Given this list of marker genes CELF2, IGSF3, RASSF4, HEY1 (NCBI Gene Id 23462), CHRND, RAPSN, POU4F1, SCN3B, JAG2, PCDH17, TNNT3, SLC24A3, MYCL, FGFR4, SEMA6A, VWF, CACNA2D2, ATP2A1, IGF2, NES, ATP2A3, CLCN5, PLXNC1, NDRG2, MYCN, NCOA1 (NCBI Gene Id 8648), FGF9, PTBP2, SYNPO2L, NCAM1, PPP1R16B, NCALD, MAB21L1, SYNE2, PCMTD2, CDH15, KCNN3, DES (NCBI Gene Id 497658), TMOD1, TFAP2B, RYR1, RRAGD, ALPK3, DCX (doublecortin), MEOX1, ZBTB18, TNNI1, AGPAT5, SIRT2, GNAS, SOX11, CHD7, POGZ, PKIA, NHLH1, EYA2, CASQ2, ITM2A, MYOG, DIO2, CHRNB1, TSPAN12, RBM38, SIK1, NRCAM, CEBPA, SGCA, PKP4, SIX1, MYL11, RPL31, ZNF536, EYA1, POPDC3, TNNI2, RTN2, TPPP3, SRSF7, ZNF106, SPINT2, ASXL2, MYOD1 (myogenic differentiation 1), BIN1 (NCBI Gene Id 274), PIPOX, TGIF2, DMPK, TUBB2B, CNR1, TNNT2, RNGTT, COBL, PDE2A, TNNC1, CDKN1C, ARPP21, ERBB3, FOXN3, CYFIP2, ENO3, here is a description of the gene set: from publication Ren YX, Finckenstein FG, Abdueva DA, Shahbazian V, Chung B, Weinberg KI, Triche TJ, Shimada H, Anderson MJ (PMID 18701482) Human Gene Set: REN_ALVEOLAR_RHABDOMYOSARCOMA_UP species: Homo sapiens Alveolar rhabdomyosarcomas (ARMS) are highly malignant soft-tissue sarcomas that arise in children, adolescents, and young adults. Although formation and expression of the PAX-FKHR fusion genes is thought to be the initiating event in this cancer, the role of PAX-FKHR in the neoplastic process remains largely unknown in a progenitor cell that is undefined. We hypothesize that PAX-FKHR determine the ARMS progenitor to the skeletal muscle lineage, which when coupled to the inactivation and/or activation of critical cell signaling pathways leads to the formation of ARMS. Because a number of studies have proposed that mesenchymal stem cells (MSC) are the progenitor for several of the sarcomas, we tested this hypothesis in MSCs. We show that PAX-FKHR induce skeletal myogenesis in MSCs by transactivating MyoD and myogenin. Despite exhibiting enhanced growth in vitro, the PAX-FKHR-expressing populations do not form colonies in soft agar or tumors in mice. Expression of dominant-negative p53, or the SV40 early region, elicits tumor formation in some of the PAX-FKHR-expressing populations. Additional activation of the Ras signaling pathway leads to highly malignant tumor formation for all of the populations. The PAX-FKHR-expressing tumors were shown to have histologic, immunohistochemical, and gene expression profiles similar to human ARMS. Our results show the critical role played by PAX-FKHR in determining the molecular, myogenic, and histologic phenotype of ARMS. More importantly, we identify MSCs as a progenitor that can give rise to ARMS. Genes commonly up-regulated in human alveolar rhabdomyosarcoma (ARMS) and its mouse model overexpressing PAX3-FOXO1 fusion.